Given this list of marker genes PGR, CXCL12, CCND1, WNT4, TNFSF11 (TNF superfamily member 11), here is a description of the gene set: Pathway Definition from KEGG: P4 -> PGR => (CCND1,TNFSF11,WNT4,CXCL12) Human Gene Set: KEGG_MEDICUS_REFERENCE_NUCLEAR_INITIATED_PROGESTERONE_SIGNALING_PATHWAY Nuclear-initiated progesterone signaling pathway. Pathway ID: N01362. Pathway type: Reference. Pathway class: nt06227 Nuclear receptor signaling. studied in species Homo sapiens